Given this list of marker genes TNFRSF21, IFRD1, TUBB6, PMAIP1, PPRC1, FBXO41, GATA6, ATG101, CASP9, MYC, TRA2B, AQP3, DUSP5, ZNF331, PHLDA2, ARPC5L, SPRED2, DNAJB1, TNFRSF11B, IER3, ARG2, SERPINB8 (NCBI Gene Id 5271), PDLIM5, JUN, DUSP10, EPHA2, PLAUR, SGK1, IRS2, MAP3K8, EGR4, JUNB, INPP1, PALLD, FUT4, SERTAD3 (SERTA domain containing 3), DUSP8, ZYX, NPC1, F2RL1, KLF6 (KLF transcription factor 6), LDLR, HOMER1, MAP3K14, JMJD6, LAMC2, CCN2 (cellular communication network factor 2), NAB2, MCL1, HERC4, PLEKHO2, TES, BCL10, FERMT2, ISG20, RARA, CCN1, WEE1, CCNL1, SEMA3B, C3orf52, GTPBP4, ID3, PPP1R15A, GEM, LRRC15, MAFF, CDC42EP3, DUSP2, FOSL1, IER2, FOSB (FosB proto-oncogene, AP-1 transcription factor subunit), AKIRIN1 (NCBI Gene Id 79647), TOB2, DST, ALOXE3 (NCBI Gene Id 64048), SIK1, TGFB2, PSME4, TNFRSF10B, TUBB2A, SOWAHC, PFKFB3, TOP1, KLF2, HILPDA, SFN (NCBI Gene Id 2810), HES1, HIC2, ARC, KLF10, ITPKC, ATF3, TNFRSF12A, SNAI2, FOS, ZNF365, SPRR1B, NR4A1, CTH, KDM6B, VEGFA, SRF (serum response factor), LYPD3, EPPK1, REL, DUSP1, GDF15, RGS2, CSNK1D, SPHK1, FLRT3, CEBPB, ETS2, IL6R, PCF11, HBEGF, SPATA2L, PWP2, EGR1, BHLHE40, GADD45A, DLX2, DDIT3, NDEL1, GATA2, FBXL12, CAMK2G, IER5, SLCO4A1, EDN1, EIF5, NAP1L1, ZFP36, CLCF1, PER1, TRIB1, SOCS1, ADM, ID1 (NCBI Gene Id 96820), JOSD1, NR4A3, KBTBD2, CXCR4, NFIL3, EGR3, STK24, USP36 (NCBI Gene Id 80160), GADD45B, LAMA3, AEN, DUSP4, CYP24A1, AREG, MIR22HG, NR4A2, MAP2K3, CGA, LIF, NEDD9, EZR, TIPARP (TCDD inducible poly(ADP-ribose) polymerase), PER2, CLDN4, VCL, AVPI1, TUFT1, EGLN3, YRDC, GAL, ZFAND5, FHL2, here is a description of the gene set: ErbB receptor ligands, epidermal growth factor (EGF) and heregulin (HRG), induce dose-dependent transient and sustained intracellular signaling, proliferation, and differentiation of MCF-7 breast cancer cells, respectively. In an effort to delineate the ligand-specific cell determination mechanism, we investigated time course gene expressions induced by EGF and HRG that induce distinct cellular phenotypes in MCF-7 cells. To analyze independently the effects of ligand dosage and time for gene expression, we developed a statistical method for estimating the two effects. Our results indicated that signal transduction pathways convey quantitative properties of the dose-dependent activation of ErbB receptor to early transcription. The results also implied that moderate changes in the expression levels of a number of genes, not the predominant regulation of a few specific genes, might cooperatively work at the early stage of the transcription for determining cell fate. However, the EGF- and HRG-induced distinct signal durations resulted in the ligand-oriented biphasic induction of proteins after 20 min. The selected gene list and HRG-induced prolonged signaling suggested that transcriptional feedback to the intracellular signaling results in a graded to biphasic response in the cell determination process and that each ErbB receptor is inextricably responsible for the control of amplitude and duration of cellular biochemical reactions. from publication Nagashima T, Shimodaira H, Ide K, Nakakuki T, Tani Y, Takahashi K, Yumoto N, Hatakeyama M (PMID 17142811) species: Homo sapiens Genes up-regulated in MCF7 cells (breast cancer) after stimulation with NRG1. Human Gene Set: NAGASHIMA_NRG1_SIGNALING_UP